The following is a description of a gene set: Sensing extracellular osmolarity to initiate a change in cell activity, and spanning the membrane of the cell. Human Gene Set: GOMF_OSMOSENSOR_ACTIVITY studied in species Homo sapiens, and this is the list of marker genes: TRPA1, SCN7A, TMEM63B, TMEM63A, TMEM63C, TRPV4, PKD2L1 (NCBI Gene Id 9033)